The following is a description of a gene set: Human Gene Set: GOBP_RECEPTOR_RECYCLING studied in species Homo sapiens The process that results in the return of receptor molecules to an active state and an active cellular location after they have been stimulated by a ligand. An active state is when the receptor is ready to receive a signal., and this is the list of marker genes: NSF, LMTK2, EPS15 (epidermal growth factor receptor pathway substrate 15), TRAT1, VAMP3, PEX1, PEX10, ECE1, INPP5F, CAMLG, PEX2, ACHE, PHETA2, PHETA1, CHMP5, LDLR, PLEKHA3, EHD3, SNX16, GRIA1, SNCA (NCBI Gene Id 6622), PEX5, PEX6, PTPN1, LAMTOR1, PTPN2, KIF16B, USP9X (NCBI Gene Id 8239), ARAP1, ALS2, PEX12, SORL1, TBC1D16, CTSD, OPTN, NSG1, RAB29, SCRIB, BVES, PSEN1, AP1AR, RAMP3, PLEKHJ1, ANXA2, RAB11B, REP15 (NCBI Gene Id 387849), ARFGEF2, PCSK9